The following is a description of a gene set: studied in species Homo sapiens from publication Chen Y, Wang X (PMID 31504780) Human Gene Set: MIR6848_3P Genes predicted to be targets of miRBase v22 microRNA hsa-miR-6848-3p in miRDB v6.0 with MirTarget v4 prediction scores > 80 (high confidence targets)., and this is the list of marker genes: STARD13, KLHL42, MSANTD4, PLXNC1, CUL4B, VAPB, NELL2, RAB30, CUL1, GIPC3, SORBS3, AMMECR1L, AIF1L, FBN1, RARG, TEAD1, CRK, TASOR, PTPRD, ZNF710, NDUFC2-KCTD14, JADE3, SLC25A36, RWDD2A, TLR7, LDB2, ITPRIPL2, TMEM33, GRM7, ALX1, DNAJB1, EML5, TSPAN18, C11orf24, KCNA6, IL20, MEFV, JAK2, IGF2BP2, LIN7C, SPTBN1 (spectrin beta, non-erythrocytic 1), PIGZ, NAP1L1, ALOX12B, ALK, ARL6IP1, ADAMTS19, IKBKE, GNAS, TSNAX, MYH10, DCUN1D4, TENT4B, GPLD1, BTBD10, SUPT7L, SUMF1, TMEM263, CBLN2, UBTD2, TMEM229B, MYO1B, GPX2, KCTD14, FBXL7, TGFB2, ARL4C, MRFAP1, MRPL19, SYT14, MFSD6, PTPRT, KLF10, HLTF, ZNF839, MLF1, STK3, CNNM2, JDP2, RTP4, SPTY2D1, CLOCK, C2orf69, NRP1, BAZ2B, PPP2R2D, GRIPAP1